The following is a description of a gene set: species: Mus musculus Mouse Gene Set: GOBP_RESPONSE_TO_IONOMYCIN Any process that results in a change in state or activity of a cell or an organism (in terms of movement, secretion, enzyme production, gene expression, etc.) as a result of an ionomycin stimulus., and this is the list of marker genes: Nfatc4, Cdk4, Cav3, Zc3h12a, Plcb1, Zfp683, Foxp1